The following is a description of a gene set: Human Gene Set: KEGG_MEDICUS_VARIANT_MUTATION_CAUSED_ABERRANT_PSEN_TO_MGLUR5_CA2_APOPTOTIC_PATHWAY Mutation-caused aberrant PSEN to mGluR5-Ca2+ -apoptotic pathway. Pathway ID: N01007. Pathway type: Variant. Pathway class: nt06460 Alzheimer disease. Pathway Definition from KEGG: (PSEN1*,PSEN2*) -> RYR3 -> Ca2+ -- MCU -> Ca2+(mito) -- MPTP -> CYCS == APAF1 -> CASP9 -> (CASP3,CASP7) species: Homo sapiens, and this is the list of marker genes: VDAC1, CASP9, CYCS, SLC25A4, PSEN2, CASP7 (NCBI Gene Id 840), VDAC3, APAF1, PSEN1, SLC25A6, CASP3, RYR3, VDAC2, SLC25A5, SLC25A31, MCU